Given this list of marker genes PRRC2A, EGR2, CSRNP3, DLX1, CHRM1, PCYT1B, CNGB3, ANXA2, H2AC20, PRRX1, HNF1B, FBXO24, CCDC141 (coiled-coil domain containing 141), MRAS, PLXNA2 (plexin A2), HOXD11 (homeobox D11), SLC9A7, H2AC25, LPL, CCDC91, NXPH1, NRP2, TCP11L2, RIMS2, E2F3, HOXA7, CSMD3, EBF2, GPR85 (G protein-coupled receptor 85), CXXC4, CNMD, KPNA3, NR2F1, HOXB8, SPACA9, STAT4, AK8, CEP120, TSPAN5, GNB1L, ITPR3, PAK6, SIX1, SP6 (Sp6 transcription factor), APOBEC4, REL, NEDD4, HSP90B1, CDX2, ALDH1A1, MT-CO1, KRTAP8-1, THRA, H2AC1, H3C2, RGS3, SLC6A15, DMD, C2CD5, HIVEP3, PDGFC, ZBTB32, CADM2, JUND, SEC22A, NRXN1, JKAMP, RARB, POLM (NCBI Gene Id 27434), SRSF1, AMER1, NFIA, CHD6, MAP2K6, VPREB3, ATP2A2, H2BC1, ESRRA, C10orf71, TNFRSF13B, GADD45G, COL11A2, COL12A1, SIK2, NR2C2, ADNP2, OR10J1, LRRN1, STAC2, SLC39A13, COL25A1, MT-CO2, SLC25A35, MAP2 (microtubule associated protein 2), GRIA3, SOX5, VAMP3, ARMC6, NFYB, KLF15, CNTF, ODAPH, DOK3, PROKR2 (prokineticin receptor 2), PIM2 (NCBI Gene Id 11040), RTL10, SPIB, LMO3, FOXP2, PIK3CD, LYN, IL25, IRX3 (iroquois homeobox 3), ZHX2, TAS2R13, TLL2, PRKAG1, TLCD5, TCF7L1, PROM1, LDB2, SEMA6C, NOS1, TMSB4XP8, KLF12, UPK3A, PLEKHA6, GNA14, UBAP2L, FLRT3, KANSL1L, WDR33, LIF, DPYSL3 (NCBI Gene Id 54406), TMOD2, NPHP4, VSNL1, IRX2-DT, BRS3, L3HYPDH, ANKRD1, PRDM10, CADM1, VGLL3, C12orf57, TCF4, MTUS1, MID1, SLC7A11, SH3BGRL, TMSB4XP6, DTD2 (NCBI Gene Id 338013), SOCS5, H2AC4, RPP21, GAB2, ASCL3, NEUROD2, PLPPR2, H2BC4, SERTAD4, H3-3B, ITCH, BCL2, BRINP3, H2BC26, CCDC116, ADAMTS19, CSF3, ADORA1, PCDH20, TSC22D3, TBXAS1, LCOR, CDCA7, SCN3A, TSC1, TSPAN13, CDK6, ATXN7L2, IRX2, PRKCB, GUCA1C, PPP2R3A, RPS19 (NCBI Gene Id 8378), TRAF3, ADH1B, CD40LG, SATB2, TLE3, FZD4, SCML1, ZNF428, HOXA10, TAAR1, DTNA, BTK, EHF, ITPRIP, TAS2R40, ISL1, GPM6A, NPR3, PARP8, TAS2R41, ANK3, PTPN3, JCHAIN, SUCNR1, SKIDA1, NDP, JAM3, ZNF362, ESRRG, HOXC5, SUGP2, PDE4D, BLNK, CCDC71L, IRX4, KCNN3, BDNF, TRERF1, GPRC5B, FGF14, NEUROG1, PTEN, CBFA2T2, MT-ND2, RTTN, EBF1, ZBTB20, ETV1, PCDH8, PPP2R3C, IGSF21, DPF3, PHOX2B, POU2F3 (NCBI Gene Id 25833), PMEL, NRL, ADORA2A, TSNAX, SOX12, CDK2, PFKFB1, NIPBL, MANF, DLG2, SCML4, GRHL3, LRCH4, SRF, OLIG3, ARMCX4, NOL4L, HYPK, HOXA3, CRYGB, DUSP6, DLC1 (DLC1 Rho GTPase activating protein), SYVN1, PAX6, KBTBD12, HOXB3, BCORP1, TCERG1L, H2AC6, SH3GL3, PRDM1 (PR/SET domain 1), RAB26, TMSB4XP4, here is a description of the gene set: species: Homo sapiens Genes having at least one occurrence of the motif NNNNATGCAAATNAN in the regions spanning 4 kb centered on their transcription starting sites. This matches the POU2F1 transcription factor binding site V$OCT1_Q6 (v7.4 TRANSFAC). Human Gene Set: OCT1_Q6